The following is a description of a gene set: Mouse Gene Set: GOBP_COPI_COATED_VESICLE_BUDDING The evagination of a Golgi membrane, resulting in formation of a COPI-coated vesicle. species: Mus musculus, and this is the list of marker genes: Arfgap3, Tmed10, Tmed9, Gbf1, Tmed10-ps, Arfgap2